Given this list of marker genes PIK3CA, GAB1, BDNF, NTF4, PIK3R1, GRB2, NTRK2, here is a description of the gene set: Reactome Pathway: Activated NTRK2 signals through PI3K part of: Signaling by NTRK2 (TRKB) Neurotrophin receptor NTRK2 (TRKB), activated by BDNF or NTF4, activates PI3K, resulting in formation of the PIP3 secondary messenger. PIP3 activates AKT signaling, and AKT signaling activates mTOR signaling. species: Homo sapiens